Given this list of marker genes COX6A1, GEN1, CASP8, NCALD, CFLAR (NCBI Gene Id 8837), CDYL2, ACAP3 (ArfGAP with coiled-coil, ankyrin repeat and PH domains 3), CDCA7, SATB2, ITPRIPL2, BAIAP3, ITGA3, ITGAX, PLCG2, PRKCD, TFDP1, TAP1, BMF (Bcl2 modifying factor), VIM, LINC00299, CYB5D1, CD151, SLC35D2, OSBPL10, TNIP2, S100A11, R3HDM4, ADGRE5, CD44, MAGI3, RUNX3 (NCBI Gene Id 864), CORO7, GAPDH, EEIG1, CPED1, SLC25A23, BID, OR6F1, ACSF2, NAPSB, AP2S1, MNS1, RORA, NEDD4L, DAAM1, MARCKS, LGALSL, PLEKHG7, PPP1R16B, CTSA, C3orf49, MIIP, MDFIC, S100A10, BIN1, AMMECR1, BATF, CAB39, WDR82, PTPN1, TKT, PPM1L, GGA1, COTL1, CD99, LGALS1, TUBA4A, DEPDC5, ATP1A1, TGM2, BCAT1, RNF19B, TAGLN2, PPFIBP2, ITGB7, PPM1M, ZBTB32, PREX1, MAST4, TRIM8, ACP5, ZMIZ1, AKAP5, SEPTIN8, ARL14, EBI3, ANXA2, UBE2G1, GET3, BHLHE40, SPANXN3, PDCD5, RASA3, SFXN1, DNAH8, SLC1A5 (NCBI Gene Id 6510), HK1, FAS, MYO1F, PRM2, TNFRSF13B, STK38L, RBM47 (NCBI Gene Id 54502), ITGB1, TCF7, NLRC5, TRIM47, BCAS1, CD86, ZNF335, GPR25, LPXN, TRANK1, COL4A4, VOPP1, CPNE5, NRG4, TBC1D9, CD68, IL36G (NCBI Gene Id 56300), ECE1, AKR7A3, TAX1BP3, SCARB1, ZBTB7A, ATRNL1, PSEN2, TEPSIN, MAP3K7CL, CALHM2, KEAP1, GSTK1, KPNA2, CDKN2A-AS1, AHNAK, CAPN2, HMOX2, NDST1 (N-deacetylase and N-sulfotransferase 1), KLHL18, EHD1, HSH2D, TWF1, ITGAL, HMOX1, SLC7A5, TIGIT (T cell immunoreceptor with Ig and ITIM domains), GOT1L1, UTS2B, TGFBR1, HIPK2, GEMIN7, JDP2, PHGDH, TRERF1, GTDC1, MVP, PDE1B, TMEM104, TBC1D27P, NME3, HOMER3, ACOT4, CPPED1, YWHAH, NYAP2, TFEB, CHAD, ALOXE3, TLE3, ZYX, ADGRB2, ACTA2, EHD3, MYO1D (NCBI Gene Id 4642), HFE, MUC16, ATP2B4, ITGAM, CTSV (NCBI Gene Id 1515), WSCD2, WDR1, PRAMENP, PI4K2A, SYNPO, PTP4A3, CRIP1, CCHCR1, MIDN, NEK6, CAPG, CARM1, COL4A3, CS (NCBI Gene Id 94822), UBE2N, ARHGAP44, TUBB4B, TOB2, CD27, ARHGAP31, SLC5A3, here is a description of the gene set: studied in species Homo sapiens Type 1 IFNs can conditionally activate all of the signal transducers and activators of transcription molecules (STATs), including STAT4. The best-characterized signaling pathways use STAT1, however, and type 1 IFN inhibition of cell proliferation is STAT1 dependent. We report that type 1 IFNs can basally stimulate STAT1- and STAT4- dependent effects in CD8 T cells, but that CD8 T cells responding to infections of mice with lymphocytic choriomenigitis virus have elevated STAT4 and lower STAT1 expression with significant consequences for modifying the effects of type 1 IFN exposure. The phenotype was associated with preferential type 1 IFN activation of STAT4 as compared to STAT1. Stimulation through the TCR induced elevated STAT4 expression, and STAT4 was required for peak expansion of antigen-specific CD8 T cells, low STAT1 levels, and resistance to type 1 IFN-mediated inhibition of proliferation. Thus, a mechanism is discovered for regulating the consequences of type 1 IFN exposure in CD8 T cells, with STAT4 acting as a key molecule in driving optimal antigen-specific responses and overcoming STAT1-dependent inhibition of proliferation. Genes up-regulated in CD8 T cells at day 8 after LCMV infection: untreated versus interferon alpha. Human Gene Set: GSE40666_UNTREATED_VS_IFNA_STIM_EFFECTOR_CD8_TCELL_90MIN_UP from publication Gil MP, Ploquin MJ, Watford WT, Lee SH, Kim K, Wang X, Kanno Y, O'Shea JJ, Biron CA (PMID 22968462)